Given this list of marker genes FZD5, HIF1A, PGR, BHLHA15, GPAT4, GATA2, XBP1, here is a description of the gene set: Human Gene Set: GOBP_GLANDULAR_EPITHELIAL_CELL_MATURATION The developmental process, independent of morphogenetic (shape) change, that is required for a glandular epithelial cell to attain its fully functional state. A glandular epithelial cell is a columnar/cuboidal epithelial cell is a cell found in a two dimensional sheet with a free surface exposed to the lumen of a gland. studied in species Homo sapiens